The following is a description of a gene set: Human Gene Set: HP_ATRIAL_FLUTTER studied in species Homo sapiens A type of atrial arrhythmia characterized by atrial rates of between 240 and 400 beats per minute and some degree of atrioventricular node conduction block. Typically, the ventricular rate is half the atrial rate. In the EKG; atrial flutter waves are observed as sawtooth-like atrial activity. Pathophysiologically, atrial flutter is a form of atrial reentry in which there is a premature electrical impulse creates a self-propagating circuit. Atrial flutter, and this is the list of marker genes: TBX20, MYH6, CLIC2 (NCBI Gene Id 1193), GATA6, KCNK3, SCN5A, SCN3B, CORIN, MT-CYB, CITED2, DMPK, NUP155 (nucleoporin 155), PRKAG2, GATA4, TLL1, LMNA (lamin A/C), NKX2-5, TNNI3K, ACTC1, SGO1, CAPNS1